The following is a description of a gene set: Genes predicted to be targets of miRBase v22 microRNA hsa-miR-125a-3p in miRDB v6.0 with MirTarget v4 prediction scores > 80 (high confidence targets). from publication Chen Y, Wang X (PMID 31504780) Human Gene Set: MIR125A_3P species: Homo sapiens, and this is the list of marker genes: CPA3, PTCH1, KLF9, POP1, NIT1, TAOK1, CREB1, CNOT4, IFIT2, JMJD8, STAP1, CHIC1, BAZ2A, HEYL, MTFR1, OVOL1, HTR4, RGS7BP, MAP3K12, CHGB, GPRC5A, TDRP, FXR1, IGF2BP2, OXLD1, AHSA2P, SLC9A7, MEAF6, INMT, KDM4A, DACH1, NUFIP2 (nuclear FMR1 interacting protein 2), THUMPD3, GLG1, SEC14L2 (SEC14 like lipid binding 2), NSG2, MTAP, CCDC178, ITGAV, PGM3, JADE3, RNF185, NARS1, GMNC, NLK, CASTOR3P, BRCA1 (BRCA1 DNA repair associated), LAIR1, BOK, CUX2, WDFY2, PRKAG1, CERS5, DTWD1, MEX3C, DENND1A, INHBC, PRDM5, MAB21L2, VPS39, LARP4, PCDH8, PEAK1, ACP3, S100A7A, ARL1, CYB561D1, ZNF287, KRTAP1-1, FUT6, BNC2, SGK1, ZNF704, CPNE4, LIMD1 (LIM domain containing 1), DHX57, MPC2